Given this list of marker genes IGLL1, IGLC7, IGLC3, IGHG4, IGLL5, IGLC6, IGHA1, IGLC1, IGKC (NCBI Gene Id 3514), IGHG2 (NCBI Gene Id 3501), IGHG3, IGLC2, IGHG1, here is a description of the gene set: A protein complex composed of two identical immunoglobulin heavy chains of an IgG isotype and two identical immunoglobulin light chains, held together by disulfide bonds. An IgG immunoglobulin complex may be embedded in the plasma membrane or present in the extracellular space, in mucosal areas or other tissues, or circulating in the blood or lymph. species: Homo sapiens Human Gene Set: GOCC_IGG_IMMUNOGLOBULIN_COMPLEX